Given this list of marker genes Cip2a, Cox4i1, Sh2b3, Tcf7l1, Smim13, Slc20a1, mt-Tn, Tfap2a, Ehmt1 (NCBI Gene Id 77683), Arf1, Elavl2, Slc35b4, Cep170, Hsph1, Sema4a, Nab1 (NCBI Gene Id 17936), Syt3, Denr, Mrpl34, Fgf9, Gm12462, Lrwd1, Rpap3, Usp5, Apba3, Mir5627, Rgl1, Gm15173, Mir3960, Cux2, Usp42, Aak1, B230217O12Rik, E130307A14Rik, Gm15217, Sec14l1, Xpo1, Mcl1 (myeloid cell leukemia sequence 1), Lcorl, Wrn, Mapkap1, Rpl11, Txnl1 (thioredoxin-like 1), Emc1, Zic4, Sephs1, Nup93, Gja3, Lrp6, Ttc39a, Usf3, Smarca5-ps, Patl1, Phf14, Cdk17, 4930488L21Rik, Kdm1a, Ly6h, Mettl23, 4930583K01Rik, Zbtb12, Adam19, Adamts8, Birc3 (baculoviral IAP repeat-containing 3), Pard3, Kbtbd8os, Slc25a33, Dgcr8, Nudt6, Arglu1, Fam193b, Fgd5 (FYVE, RhoGEF and PH domain containing 5), Kat2b-ps, Csnk1a1, Snx27, Cdc34, Tgfbr1, Gm26592, Rrp1b, Kcns3, 5330438D12Rik, Gtpbp2, Ppp4r4, 1700022N22Rik, Slc18a3 (NCBI Gene Id 20508), Rexo2, Togaram1, Polm, Odc1, 4732491K20Rik, Mrs2 (NCBI Gene Id 380836), Kbtbd8 (NCBI Gene Id 243574), Itpr1, Nfkb2 (nuclear factor of kappa light polypeptide gene enhancer in B cells 2, p49/p100), Ppp2r5a, C2cd3, Ttc28, Zzz3, Capn15, Nfkbib, Mier2, Uhrf1, Rgl2, Mir7687, Dffa, Asns (asparagine synthetase), Gbp5, Psmc6, Tmprss12, Acad8 (NCBI Gene Id 66948), 4930518J20Rik, Osbpl2, Gm10244, Nrk, Glrx2, Gm19684, Abhd17a, Psmd10, Mitf, Fgd6, Cbx3, Chmp4b (NCBI Gene Id 96954), Fam13c, Tfeb, Fbxo41, H60b, Zfp513, Slc6a8, Rras, Lypla1, Wrap73, Map2, Zfp382, Cdip1, Ipo13, Rps2-ps11, Akap10, Tpgs2, Sirt2, Otop1, Zfas1, H2-T10, Phf13, Cacna1h, Zfyve1, Rangap1, Jmjd6, Tnnt1, Zc3h7a, Crebrf, Bcl2l12, Pde10a, Pgk1, Dimt1, D030047H15Rik, Nprl2, Gm13162, Usf2, Rnf26rt, Clcn6, Pdik1l, Gm12101, Mme, Zw10, Gm15634, Hook3, Mir3113, Polr3e, Ppme1, Zdhhc17, Notch1, Phyhipl, Zcchc24, Mrto4, Ubqln1, Scrib, Gm10222, Wdfy1, Kmt2b, Syde2 (synapse defective 1, Rho GTPase, homolog 2 (C. elegans)), Erc1, Nup58, 5430405H02Rik, Cspg5, 1700003G18Rik, Zfp213, Xpo6, Adipor1, Fam20c, Mtarc2, Dock9, Rps19bp1, Trim2, Rhot1, Rnf139, Casp3, Acbd5, Igsf11, Trim44, Max, Pa2g4, Septin9, Cyp46a1, Tmem135, Peds1, Ubr4, Myb, 1810062O18Rik, Sntb2, Plek2, 1700034P13Rik, Cdk9, Stx1b, Rel, Mrps25, Ralgds (NCBI Gene Id 19730), Otulin, Stam, Crbn, Slc38a2, Rreb1, Ddx6, Abhd10, Usp35, Ero1b, Cdc26, Acvr1c, Ndufab1, Fhl4, Gm14662, Trim59, Gm29417, Ncoa2, Gm11240, 2310001K24Rik, Ctcf, Dzip3, Ccpg1, Zfp580 (NCBI Gene Id 68992), Dsel, Nop14, Rab8b, Amfr, Arfrp1, Srr, Serpini1 (serine (or cysteine) peptidase inhibitor, clade I, member 1), Sft2d2, Nfib, Pds5a, Gm6556, Dlgap2, Mir8104 (microRNA 8104), 2310010J17Rik, Ttc39aos1, Leng8, Pgap6, Rnf103, Ypel3, Nfkbiz, Rab5c (NCBI Gene Id 19345), Tmcc2, Gm4285, Capn5, Sppl3, Stk31, Gins1, Purg, mt-Tq, Vrk1, Dok6, Nod2, mt-Nd2, Dazap1, Ube3a, Vcpip1 (NCBI Gene Id 70675), Sgcd, D030056L22Rik, Thrap3, Kcnma1, Josd1, Ubac1, Kcnn2, Six2, Dr1, Ubxn2a, Cdc6, Pld3, Asxl1, Whrn, Uggt2, Pdcd10, Prkd3, Pygo1, Ndc1, Gatad2a, Zfp444, Clptm1l, Gm13880, Zfp236, Prcd, Tlr2, Ascc1, Zfp318, Snrk, Lamtor2, H1f10, Gls, 1700104B16Rik, Khdrbs1 (NCBI Gene Id 20218), Gtf2i, Phf12, Neil1, Cant1, Macroh2a1, Ddx23, Selenoi, Pafah2, Gm26588, Dnajc17, Gm15473, Fkbp10, Ppp2r2d, Kctd12, Usp13, Gm20753, Brd3, Rb1, Pdss1, Pld5, Fgfr2, Gtf2e2, Lingo1, Pum2, P4ha3, Ino80dos, Gm12428, Entpd5, Hand2os1, Btbd6, Akirin2, Zgpat, Cdca3, mt-Tc, Pemt, Ywhag, Xkr6, Sdk2, Ppp2r5e (protein phosphatase 2, regulatory subunit B', epsilon), Rnf170, Cdc73, Tmem129, Gps1, Zc3h15, Mpc2, Psmd3, Gpalpp1, Otud3, Lrrc1, Gm13830, Aplf, Tmem132d, Med17, Mtcl2, Gm10516, Mir7671, Rpgrip1l, Rab29, Senp2, Bub1b, Aamp, Brdt, Cpeb3, Erp44, Foxa3, Tafa5, Arf4os (NCBI Gene Id 791355), Inpp5k, Glyr1, Ctdp1, Tpt1, Phtf1, Ccdc124, Mir1945, Fa2h, 4930417H01Rik, Blcap (NCBI Gene Id 98987), Gorasp2, Timm21, Nudt13, Huwe1, Pierce2, Sec11c, Chmp7, Hcn3, Agap1, Zfp641, Bcat1, Map3k10, Rasal3, Pde5a, Snx1, Srgap1, Smyd2, Zcchc8, Atp23, Ei24, Kansl1, Cers1, Mxi1, Kbtbd7, N4bp1, Hlf, Rce1, Fyco1 (NCBI Gene Id 70204), Hbp1, Aga, Ap2s1, 4930578M01Rik, Gm15564, Esrrg, Nox4, Glrb, Trpc3, Jdp2, Sfi1, Marchf5, Proser1, Ahdc1, 6330562C20Rik, Rsad2, Cfap97, Zfp696, Ifrd2, Igf2os, Crmp1, Ap2m1, Acvr1, 1700027A07Rik, Rprd1b, Rbl2, Tes, Shisa7, Sdccag8, Mn1, Tprg1l, Gm13736, Zfp787, Mir219a-2, Slc31a2, Smoc1, Arv1, Gm4890, Zbtb43, mt-Co2, Snx10, Ccl3, Plekhm2, R3hcc1l, Smoc2, Adss1, Fras1, Nek6, Arhgap22, Crocc, Cep192, Gm12536, Glis3, Upp2, Tnf, Luc7l, Polg, Mpdz, Mrpl32, Tenm1, Cdkn2aip, 2010110E17Rik (RIKEN cDNA 2010110E17 gene), Cbln1, Fam193a, Tpr, Gspt1, Thap2, Gm20760, 9030622O22Rik, P3h4, Ciao2a, Thoc3, Srrm2, Gid4, 0610009L18Rik, Ubqln4, Gm27021, Tdrd5, Hfm1, Sprtn (NCBI Gene Id 244666), Mapk1ip1, Ankrd13b, Zmat5, Abhd12, Fbn1, Csnk2b, Agps, mt-Td (mitochondrially encoded tRNA aspartic acid), Sp3os, Tgif2-ps2, Nsd3, Tacc1, Hmbox1, Ralbp1, Ajap1, Glcci1, Fgf22, Banp, Creld2, Zdhhc8, Fkbp8, Fzd6, Otud4, Tial1, Pak2, Ap5s1, Npffr1, Hepacam2, Tmem267, Mthfr, Ss18, Pdcd6ip, Gm23205, Tubd1, Trps1, Gbp2, Tmem147, Tmbim1, Matr3, Gm26854, Btrc, Gmpr2, Rpl8, Rdh14, Sdhaf2, Tgfbrap1, Noc2l, Phlpp1, Gm15535, Gabpb1, Zfp189, Senp3, Zfp637, Slc22a5, Garem2, Mir6935 (NCBI Gene Id 102465564), 1700007L15Rik, Kdm6b (NCBI Gene Id 216850), Ncoa3, Aatf, Gpank1, Ubfd1, Calcoco1, Uncx, Guk1, Bod1, Ppm1f, Gm2464, Srsf9, Nkpd1, Far1, Bhlhe41, Tnip1, 9530036O11Rik, Slc30a4, Cdk5, Dynll1 (dynein light chain LC8-type 1), Dnajb9, Swt1 (SWT1 RNA endoribonuclease homolog (S. cerevisiae)), Smarcal1, Nova1, Mon2, Gatb, Stradb, Camk2d (calcium/calmodulin-dependent protein kinase II, delta), Actg1, 4931415C17Rik, Faf1, Alyref2, Grb10, Zfp451, Gm25878, Btf3l4, Fam53b, Cnot4, Adipor2, Zfp36l2, Rapgef2, Gstz1, Vstm4, Prpf4, 1700030K09Rik, 2610042L04Rik, Picalm, Slc15a4, Cibar1, Gsk3a, Spata1, Pnldc1 (NCBI Gene Id 240023), Sclt1, Hps5, Myl12b, D930007P13Rik, Scaf1, Rasgrf2, C330018D20Rik, Cep128, C130060C02Rik, Chst10, Zbtb25, Snrpa1, Ptprm, Pex5l, Kdelr2, Crtc2, B230219D22Rik, Mbtps1, Podxl2, 1700003M07Rik, Zfc3h1, Dpm2, Egr1, Timm22, Atp2b1, Rab1a, Klhl8, Yars2, Dusp2, Srprb, 4930515G01Rik, Desi2, Fermt2, Zfand5, Cdca4, Cdv3, Pgls, Gm9945, Scara3, Cyb561, Invs, Nnat, Znfx1, Bambi, Srsf5, Gadd45b, Gm26330, Arpc5, Snx3, D3Ertd751e, Pls1, Gm26704, Ptdss2, Elfn2, Aldh16a1, Tub, Ptp4a2, Arhgap42, Gfra4, Mrpl39, Sap18, Actb, Smim30, Bbof1, Morf4l1, 4632404H12Rik, Cers2, Cacna2d2, Rpia, Wasf2, Stau1, Cftr, Fam136a, Yjefn3, Sos2, 4930455B14Rik, Trmt1l, Pde6d, Adamts19, Wnk1, Cdk19, Aplp1, Snapc3, Golgb1, Mir3569, Mir1938, Gm9887, 9430015G10Rik, Tmem147os, AW554918, Gm8258, 1700017B05Rik, Taf11, Psmd14, 2810032G03Rik (NCBI Gene Id 72669), Rhbdd2, Cmtm6, Rnf114, Cnot1, Mkrn1, Mir8098, Mir7012, Zbtb1 (NCBI Gene Id 328127), Nlgn2, Bcr (NCBI Gene Id 71258), Uqcr10, Tmem43, Crtac1, Arpc1b, 2810459M11Rik, Slc4a4, Fiz1, Kctd1, Fzd9, Zfand3, Cnbd2, 2310058D17Rik, Gm17115, Zhx3, Calb2, N4bp2l2, Nedd8, Map3k8, Tmem11 (transmembrane protein 11), Cfap20dc, Med16, Clk2 (CDC-like kinase 2), Tnfaip3, Ccdc18, Pan3, Nck2, Vezt, Sharpin, Ahctf1, Kctd21, Gm10555, Slc4a3, Pusl1, Foxo3, Crk, Brms1l, Ormdl3, Fhad1, Sav1, Thap4, Ankrd17, Xylt2, Primpol, Tulp4, 1700016A09Rik, Thyn1, Asap1, Arf4, Mir2861, Nhlrc3, Foxred2, B230208B08Rik, Naa15, Cdkl3, Abcb4, Peli1, Wbp4, Wdpcp, Maf1, Cryzl1, 9330154J02Rik, Golga5, Tpst2, Nsun2, Eme2, Zfp148, Slc27a2, Rhno1, Gnao1, Fdps (farnesyl diphosphate synthetase), Tmub1, Gm27003, Psd3, Rusc2, 2310022A10Rik, Gng5, Snord55, Ino80d, Gm11837, Lars1, Fbxo46, Gdpd5, Cep104, Bcan, Ptgfrn, Adam17, mt-Ta, Gm13161, Dis3l, Prmt7, Gm9967, 1110004F10Rik, Cacna2d1, Josd2, Lif, Fbxw11, Cdc25a, Rbm17, Setd6, Ncald, Rc3h1, Mrpl50, Fgfr3, Gm14320, Sgsm2, Gm16230, Prex2, Hsp90b1, Fam171a2, Wfdc3 (NCBI Gene Id 76647), Mrpl48, Rnf128, Plag1, 1700042D02Rik, Zfp260, Tex30, Rpl31, Mtnap1, Vars2, Des, Wtap, Dennd1a, A830082K12Rik, P3h2, Col19a1, Usp40 (NCBI Gene Id 227334), Slfn3, Igf2, Cerox1, 1110019D14Rik, Rab35, Cops7b, Tnfaip1, Ssx2ip, Mbnl1, Anks1, Hdhd5, Atp5f1e, Ube3c, Bves, Cnnm4, Sar1a, Tsr1, Helz, Zfr, Adra1d (NCBI Gene Id 11550), Nat8l, Camsap2, Cpm, 3110070M22Rik, Wdr5, Ctbp2, Gtf2h1, Plagl2, Npas3, Rest, Tmem214, Prss36, Ppp3cb, Pde4dip, Dusp22, Gm17259 (NCBI Gene Id 100502757), Tmed2, Arhgap44, Fto, Tamm41, Colec12, Kpna3, Usp4, Chkb, Gpc1, Ppp2r5b, Bmi1, Anapc16, Lats1, Nhs (NCBI Gene Id 636822), Lsm14a, Fyn, Kpna1, Hspa13, A430035B10Rik, Ccdc163, Arfip1, Cgas, Anks1b, Lpar3, Gm10308, Marcksl1-ps5, Plxnb1, Rfng, Ece2, 4930449I04Rik, Trak2, Rcan2, Crebl2, Sox8, Hscb (NCBI Gene Id 231610), Epn1, E230015B07Rik, Eny2, Abcd3, Ndufa6, Vps54, Tacc3, Tsga10, Dnttip1, 2500004C02Rik, Dync1i2, Rogdi, Aff2, Rhbdl3, Zfp777, Chrac1, Phtf1os, Cdh2, Txndc12, Sf3b2, Camta1, Gm7467, Nutf2, Tmem115, Pofut1, Nmt1, Azi2, Dlgap1, Ralgapb, Tmed5, 6430573P05Rik, Prdm15 (PR domain containing 15), Slc4a2, Shisa8, Dagla, Papola, Tle3, Gmfg, Dcakd, Zdhhc21, Zfp871, Arap1, Nufip1, Krt7, Ptges2, Tarbp2, Kat2a, 2310074N15Rik, Tmpo, Zbtb44, Exoc6b, Usp48, Gtf2h4, Plekha1, Nrxn1, Prcc, Sec61a1, Snx25, Pde11a, 4930579G24Rik, Ino80, Lepr, Tsku (NCBI Gene Id 244152), Mir9-3, Prdm11, 1810012K16Rik, Aup1, Klc1, Mtmr7, Luc7l3 (NCBI Gene Id 67684), Nemp1, Cct5, Llgl1, Qtrt2, Zdhhc14 (zinc finger, DHHC domain containing 14), Htra3, Tspan18, Setd1b, Taf9b, Clock, Slc2a3, Smg7, Prkacb, A330102I10Rik, Atp1b1, Gm16136, Syndig1, 1110006O24Rik, Smpd3, Actr3, Stim2, Acsl1, Ankrd34b, Fem1a, Ttc13, 4930589O11Rik, Zfyve19, Mmachc (methylmalonic aciduria cblC type, with homocystinuria), Stx16, Tcerg1l, Nfkbia, Zcwpw2, Birc5, Alkbh4, Rabac1, Osbpl1a, Slc27a4, Thrb (thyroid hormone receptor beta), Zfp664, Ado, Rnf44, Ttc39d, Card10, Fam171a1, Synj2 (NCBI Gene Id 20975), Zfp933, Ndufv2, B230354K17Rik, Kcnd3os, Npdc1, Slc1a2, Ncoa5, Mbd3, Slc35f3, Wscd2, Rnf111, Pparg, Atpaf2, Nfxl1, Rflna, St8sia5, Emsy, Pcmt1, Tmem30b, Tapt1, Mmaa, Gm7008 (NCBI Gene Id 638458), Uba2, Vipas39, Iftap, Gm6420, Ptprd, Pygo2, Ythdf1, Spock1, Mir193a, C230012O17Rik, Cmas, 4930513N10Rik, Dhx33, Psma2, Cep290, Msh6, Gm11978, Gm27032 (predicted gene, 27032), Chek2, Ap5b1, Irf2bp1, Rxrb, Gbe1, Gm5577, Setmar, Plk5, 1700008O03Rik, Gas7, Irf3, Eml6, Strbp, Katnal1, Sp3, Mturn, Tmtc3, Klf13, Gm10069, Ubtf, Tmcc3, Wbp2, Tcf7l2, AI480526, Dcp1b, Kcnd3, Tbc1d10b, Tmem131, Ikbke, Fhip2a, Ccdc146, Atg4b, Asic2, Pnkd, Fam185a, Car11 (carbonic anhydrase 11), mt-Ty, Odr4, Ppp6c, Kcna3, Ranbp17, Adpgk, Dcps, Gm19569, Slc12a5, Ralgapa2, Rpl18, Rims3, Atpsckmt, Wdr4, Med26, Tmem160, Chchd4, Sphk2 (sphingosine kinase 2), Zfp369, Slc9a8, Ric8b, Klhl28, Haus6, Slc35a1, Abcf2, Rps8, Zfp219, Fscn1, Rasd2, Timm13, Unk, Kctd20, Krr1 (KRR1, small subunit (SSU) processome component, homolog (yeast)), Wdr87-ps, Wdfy2, Lair1, Mir7654, Apbb2, Vdac3, Mgll, Igfbp4, Tmem263, Arl10, Acap3, Atg4a, Kif20b, Tmem41b, Vldlr, Gm3510 (predicted gene 3510), Casz1, Gm13231, Xxylt1, Ccdc191, Tatdn1, Clpb, Heyl, Impdh1, Etnk1, Stx11 (NCBI Gene Id 74732), Fbxo9, Kxd1, Alg11, Fkbp4, Sipa1l3, Xpot, Gpr108, Gm2990, Gm5909, Rad18, Plcb4, Nrde2, Tnfsf13os, Cnot2, Naa30, Hace1, Chchd7, Gm16437, Msl3, Mtmr2, Mlf1, Chrna7, AI597479, Ccdc92, Alg12, Oxr1, Slc39a7, Ncln, Smg1, Ddah1, Tti1, Itsn1, Kbtbd2, Sesn1, Rab3ip, Atp7b, Dusp26, Scaf4, Crip2, Stamos, Gnaq, Zfp24, Tnpo2, Fbrsl1, Afg2a, Ift20, Unc80, Etfdh, Trim39, Mrpl45, Rab3d, Adgrl3, Ark2c, Dchs1 (dachsous cadherin related 1), mt-Tw, Grk4, Ston2, Lmo2, 9130401M01Rik (RIKEN cDNA 9130401M01 gene), Rasef, Man1a2, Sympk, Pih1d1, Elob, Mycl, Ahsa1, 9430038I01Rik, Rnf38, Tspan14, Nfatc3, Dnajc6, Serbp1, Fgf3, Hnrnpa2b1, Set, Dcaf13, Ablim2, Ctdspl, Gm11889, Snx9, Nrsn1, Wrnip1 (Werner helicase interacting protein 1), Htra2, Abr, Sycp1, Ndufb9, 4930444P10Rik, Dhx8, 4930524B15Rik, Dab2ip, Tmem183a, Vps50, Hcfc2, Clint1, St7, Rell1, Fam131b, Cic, Pom121, Stx4a, Arhgap29, 2810414N06Rik, Qser1, Epc2 (enhancer of polycomb homolog 2), Ears2, 3110082J24Rik, Adgre1, Snx8, Gm2415, Ermp1, Stxbp5, Fam234b, Enpp4, Flvcr1, Ifrd1, Gtf2ird2, Tbl1xr1, Rc3h2, Cilk1, Ube2q1, Crtc1, Calr3, Epha5, Unkl, Rab14, Srrm1, Emc8, Slc39a14, Nr3c1, M6pr, Rbm6, Slc30a5 (NCBI Gene Id 69048), Ints9, Bend3, Tubgcp3, Slc7a6os, Irx2, Dop1a, Prmt6, Cyb561d2, here is a description of the gene set: Genes containing one or more binding sites for (Zfp652) in their promoter regions (TSS -1000,+100 bp) as identified by GTRD version 20.06 ChIP-seq harmonization. Mouse Gene Set: ZFP652_TARGET_GENES from publication Yevshin I, Sharipov R, Kolmykov S, Kondrakhin Y, Kolpakov F (PMID 30445619) studied in species Mus musculus